The following is a description of a gene set: from publication Lien HC, Hsiao YH, Lin YS, Yao YT, Juan HF, Kuo WH, Hung MC, Chang KJ, Hsieh FJ (PMID 17603561) Metaplastic carcinoma of the breast (MCB) is a poorly understood subtype of breast cancer. It is generally characterized by the coexistence of ductal carcinomatous and transdifferentiated sarcomatous components, but the underlying molecular alterations, possibly related to epithelial-mesenchymal transition (EMT), remain elusive. We performed transcriptional profiling using half-a-genome oligonucleotide microarrays to elucidate genetic profiles of MCBs and their differences to those of ductal carcinoma of breasts (DCBs) using discarded specimens of four MCBs and 34 DCBs. Unsupervised clustering disclosed distinctive expression profiles between MCBs and DCBs. Supervised analysis identified gene signatures discriminating MCBs from DCBs and between MCB subclasses. Notably, many of the discriminator genes were associated with downregulation of epithelial phenotypes and with synthesis, remodeling and adhesion of extracellular matrix, with some of them have known or inferred roles related to EMT. Importantly, several of the discriminator genes were upregulated in a mutant Snail-transfected MCF7 cell known to exhibit features of EMT, thereby indicating a crucial role for EMT in the pathogenesis of MCBs. Finally, the identification of SPARC and vimentin as poor prognostic factors reinforced the role of EMT in cancer progression. These data advance our understanding of MCB and offer clues to the molecular alterations underlying EMT. Genes up-regulated in metaplastic carcinoma of the breast (MCB) subclass 2 compared to the MCB subclass 1. species: Homo sapiens Human Gene Set: LIEN_BREAST_CARCINOMA_METAPLASTIC, and this is the list of marker genes: MMP16, PRRX1, THBS1, KCNE4, COL18A1, POSTN, SPARC, RUNX1T1, SFRP2, MCAM, THBS2, TPM4, IGF2, PDGFA, HTRA3, TIMP3, MXRA8, MSX1, HOXA7, IQCA1, RARRES2, LUM, EDIL3, PPP1R12A, PDGFRA, PKD2, ACAN, STAG2, P4HB, TBX2, ADAMTS5, COL16A1, TMEM217